The following is a description of a gene set: species: Homo sapiens Abnormal iliac wing morphology Human Gene Set: HP_ABNORMAL_ILIAC_WING_MORPHOLOGY An anomaly of the ilium ala. This is the large expanded portion of the ilum which bounds the greater pelvis laterally., and this is the list of marker genes: GALNS, MATN3, HDAC6, RPS6KA3, COL2A1, DYM, VPS33A, FUZ, TBX15 (T-box transcription factor 15), RAB23, AMER1, SEC23A, FGFR3, RTL1, ERCC8, FLNA, BGN, LAMA5, EP300, CCBE1, B3GALT6, VANGL1, ARSB, IDUA, PLEKHM1, EZH2, GNPTG (NCBI Gene Id 84572), AIFM1, SOX9, COL9A1, MMP13, ZBTB20, SEC24D, GNPTAB, CTSK, FN1, NKX3-2, RUNX2, DDR2, MEG3, EVC2, PCNT, SMAD4, NANS, EVC, ATP7A, GPC3, GPC4, COL11A2, GPX4, PHEX, RIPK4, LYSET, CREBBP, PTH1R, GUSB, ERCC6, TRPV4, RNU4ATAC, WNT7A, DLK1, EED, TRIP11, TRAPPC2, PEX5, GLB1, EIF2AK3, IHH